The following is a description of a gene set: from publication Duraiswamy J, Ibegbu CC, Masopust D, Miller JD, Araki K, Doho GH, Tata P, Gupta S, Zilliox MJ, Nakaya HI, Pulendran B, Haining WN, Freeman GJ, Ahmed R (PMID 21383243) Human Gene Set: GSE26495_PD1HIGH_VS_PD1LOW_CD8_TCELL_UP species: Homo sapiens T cell dysfunction is an important feature of many chronic viral infections. In particular, it was shown that PD-1 regulates T cell dysfunction during chronic LCMV infection in mice and PD-1 high cells exhibit an intense exhausted gene signature. These findings were extended to human chronic infections such as HIV, HCV and HBV. However, it is not known if PD-1 high cells of healthy humans have the traits of exhausted cells. In this study, we provide a comprehensive description of phenotype, function and gene expression profiles of PD-1 high versus PD-1 low CD8 T cells in the peripheral blood of healthy human adults as following: 1) The percentage of naive and memory CD8 T cells varied widely in the peripheral blood cells of healthy humans and PD-1 was expressed by the memory CD8 T cells. 2) PD-1 high CD8 T cells in healthy humans did not significantly correlated with the PD-1 high exhausted gene signature of HIV specific human CD8 T cells or chronic LCMV specific CD8 T cells from mice. 3) PD-1 expression did not directly affect the ability of CD8 T cells to secrete cytokines in healthy adults. 4) PD-1 was expressed by the effector memory (TEM) compared to ‘terminally differentiated effector’ (TEMRA) CD8 T cells. 5) Finally, an interesting inverse relationship between CD45RA and PD-1 expression was observed. Genes up-regulated in comparison of PD-1 high CD8 T cells versus PD-1 low CD8 T cells., and this is the list of marker genes: ZNF862, GPR183, SCARB1, FSD1, ZNF329, SF1, SLC4A3, LINC02877, TCL1A, FOXM1, C16orf54, PTPRB, ZBTB8B, PDZK1IP1, TNFRSF10B, ELOCP28, NUP188, TRAIP, GVQW3, TTC9, ABTB2, TRMT44, FOXO1, EIF3L, FYN, PDCD4, TBC1D4, ZIK1, GNAS-AS1, STON1, STK33, ETS1, PNPLA5, NCK2, COQ8A, SLC23A2, LPCAT2, ADAMTS17, P2RX5, NDNF, PHGDH, BICDL1, THEMIS, STPG4, KHDC1, SARAF, RNF214, SLC8B1, BLVRA, CCL20, EME2, KIRREL3-AS3, KANK2, KRT8, TAS2R1, LRTOMT, TCF7, BTN2A1 (NCBI Gene Id 11120), NLRP13, VCAM1, HNRNPLL, SLC35G2, CBFA2T2, TNFSF8, ZNF335, SH3GL1P2, TRAT1, MCF2L-AS1, MAN1C1 (NCBI Gene Id 57134), ITIH3, SLC43A3, LMBR1L, ANKRD23, GSR, GALM, GARIN1A, CCL23, DGKH, SGPP2 (NCBI Gene Id 130367), ARHGAP35, TMEM63C, ZNF583, PLXND1, SUGT1P3, RPL23AP32, TIMM44, ABCG2, LINC01569 (NCBI Gene Id 100507501), MIR155HG, ATP6V1G2, PURPL, PIM2, MMEL1, ZNF512B, USP36, BPHL, GBP5, FAM149A, EVC2, PTPRK, CCDC169, CCR4, RTN4R, ZNF101, RANBP9, MMACHC, RPS16, C22orf15, MYH2, TRBC1, GTPBP3, ST8SIA1, TMEM170A, LPCAT4, RXFP3, HLA-DOA, SPINK7, KCNJ14, RFPL3, ANK2, BRCA1, ICOS (NCBI Gene Id 29851), POU2F3, BBS1, MBD1 (methyl-CpG binding domain protein 1), TMC6, HAUS5, E2F3, LRIG1, CNNM3, ENSG00000213963 (NCBI Gene Id 285023), ZP2, PDIA5, IL22, WRAP73, AMPD3, PTPN13, CECR3, ING5, KRTAP2-4 (NCBI Gene Id 85297), ZNF587 (NCBI Gene Id 84914), TMCC2, EOGT, PLCG1, INMT, PRDM6, PDCD1, MYO1A, PBXIP1, SLAMF1, FANCD2, MEGF6, NAT9, ZNF839, ITGA6, JMJD8, CKAP2L, RNASET2, HINT1, SLC52A1, GAMT, CD28, TNFRSF14, AOC3, SEPTIN6, SIRPG, LRCH2, UBA7, PRG4 (proteoglycan 4), C15orf40, CD27, GZMK (granzyme K), NELL2, ZNF419, OLFM4, CCDC62 (coiled-coil domain containing 62), PINX1, LINC01550, GDPD3, MYRIP, KCNQ1, LINC02731, LDLRAP1, AMIGO1, C1orf167, ITGB2-AS1, PLA2G2F, GLCCI1, NOC2L, IL4, ACOT9, ADPRHL1